Given this list of marker genes Gpat4, Tyms, Pgr, Gata2, Tgfb1, Xbp1, Gja1, Cdkn1a, Bhlha15, Tmigd1, Fzd5, Hif1a, Hoxa5, Kcnma1, here is a description of the gene set: The developmental process, independent of morphogenetic (shape) change, that is required for a columna/cuboidal epithelial cell to attain its fully functional state. A columnar/cuboidal epithelial cell is a cell usually found in a two dimensional sheet with a free surface. Columnar/cuboidal epithelial cells take on the shape of a column or cube. species: Mus musculus Mouse Gene Set: GOBP_COLUMNAR_CUBOIDAL_EPITHELIAL_CELL_MATURATION